Given this list of marker genes FURIN, GBF1, TSG101, NCL, DENCMEMSB, LYN, YBX1, CLINT1, KDELR1, here is a description of the gene set: Reactome Pathway: Assembly and Release of Dengue Virus Virions species: Homo sapiens The newly synthesized Dengue virus (DENV) positive-sense RNA (+ssRNA) genomes are packaged into viral particles in the endoplasmic reticulum (ER), where they associate with the structural viral proteins C, prM, and E. The immature viral particles are transported through the Golgi apparatus to exocytic vesicles, where prM is cleaved to form mature virions. In mature virions, E is organized as 90 head-to-tail orientated dimers of E:M heterodimers, which lie in sets of three, nearly parallel to each other and to the viral surface, forming a smooth ‘‘herringbone’’ configuration (E:M:M:E; reviewed in Rodenhuis-Zybert et al. 2010). Three E:M:M:E tetramers present in each icosahedral asymmetric unit exist in three chemically distinct environments and may therefore play a distinct role in different stages of the infection. The mature virions are released from the cell via exocytosis. part of: Dengue Virus Infection